Given this list of marker genes FOXP3, DCLRE1C (DNA cross-link repair 1C), DOCK11, BLM, CD3E, ADAT3, SLC35C1, IRF9, CD3G, MAN2B1, VPS33A, SP110 (SP110 nuclear body protein), EGFR, ADAM17, here is a description of the gene set: Human Gene Set: HP_RECURRENT_GASTROENTERITIS Recurrent gastroenteritis species: Homo sapiens Increased susceptibility to gastroenteritis, an infectious inflammationof the stomach and small intestines manifested by signs and symptoms such as diarheas and abdominal pain, as manifested by recurrent episodes of gastroenteritis.